The following is a description of a gene set: Genes predicted to be targets of miRBase v22 microRNA hsa-miR-544b in miRDB v6.0 with MirTarget v4 prediction scores > 80 (high confidence targets). from publication Chen Y, Wang X (PMID 31504780) Human Gene Set: MIR544B studied in species Homo sapiens, and this is the list of marker genes: KLC4, SP110, PBX2, CACUL1, HEPH, ZNF704, CHST14, MAP3K1 (NCBI Gene Id 4214), MAPK8IP3, NUFIP2, UBR3, BLMH, MAP3K3, ABHD3, SGPL1, COX20 (NCBI Gene Id 116228), THRB, COL4A2, TINF2, DNAJC27, ESRRG, ARSD, ERVH48-1, RASSF5, CEP20, RPS6KL1, ARPP19, SMARCD1, ELAVL1, FSD1L, SLC2A12 (NCBI Gene Id 155191), MYT1, RBM41, PTPN1, ENTPD4, FNTB, GLT8D1, ACTL6A, IPMK, CCDC57, ZNF558, TAFAZZIN, CHIC1, MEMO1, IPO9, PPP3CA, TENT4B, RETREG2, PUS1, ARIH1, PTGR3, IRS1, C1orf210, BRMS1L, SCML2, SLC44A1, MYCBP2, NCOA3, RGL1, MMP14, RPEL1, ELOVL1, CMTM7, PCGF3, PCTP, MBD3, CREM, LYSET, XPNPEP3, TGFBR2, SLC26A6, AMIGO1, BCL2L2, CUL1, KCNIP3, CASKIN1, ZNF76, RBM7, OR51E1, LIMD1, ITGA1, ZNF322, WSCD2, CACNG3, FAM118A, CBX2, RAD54L2, DICER1, IRX2, ARRDC4, RAB32, DMRT3, KCTD15, ABCG8, LDB2, CFAP184, IGDCC3, ANKRD33B, FOXK1, SH3BP4, MGA, DCAF12L2, ALDH6A1, ADAMTS15, KIAA1671, SLC14A1, CCND2, SEMA4C, TRPV3, MINPP1, CNNM2, HDAC7, PPP6R3, LYN, UHRF2, TM9SF4, DMXL1, IGF2BP3, FBXO45, MICOS10, JAKMIP3, CAND2, UBFD1, PSME3, ATP11C, KLHL28, ANO3, DHX35, ATP2B1, AP4E1, SHISAL1, PTPN7, INSR, PDE3B, IRF2, VDR (NCBI Gene Id 7421), CASP6, ZNF609, KIF21A, ARMC1, KMT5C, HAPLN4, CORO2A, ESYT1, BLTP3A, HDAC6, ADA2, PLXNA2, HDLBP, DOCK11, HOMER1, CEP164, PPP2R3A, TRIL, SECISBP2L, HIP1, CYB5R4, ARID1A, ABCC5, GMCL1, TMEM41B, ELMOD2, FYCO1, SPG11, KLF13, STK4, ZFYVE28, ARNT, CHFR, ZNF616, PIP5K1A, BMP2, ZIC3, HMOX2, CEP85, PTK2, FBN3, PLXNA4, ZNF841, LPP, H2AZ1, TEX38, EML1, SMARCC1, NR6A1, ELFN2, NDST3, PITPNC1, CCDC13, PPP4R3B, PIP4P2, CACNA1I, USP33, HDX, SOS2, CCDC62, HNF4G, ADAM10, PLCXD3, LOXL4, ZNF264, FEN1 (flap structure-specific endonuclease 1), KLHL6, LOXL3, SLC38A7, PLEKHG4B, SRC, TBC1D9B, ZNF646, ERCC6L2 (ERCC excision repair 6 like 2), ADAM8 (NCBI Gene Id 101), PAN3, MMP24, HTT, RAB11FIP2, CIAO2A, AFG2A, IRGQ (NCBI Gene Id 126298), HTATIP2, WASHC4